Given this list of marker genes Polr3gl, Polr2l, Pou2f1 (POU domain, class 2, transcription factor 1), Gtf3c5, Polr2f, Polr3c, Polr3g, Snapc2, Polr3h, Snapc4, Gtf3c2, Polr2k, Gtf3a, Gtf3c6, Snapc1, Polr3d, Bdp1, Polr3f, Brf2, Snapc5, Polr1c, Gtf3c3, Gtf3c1, Polr2h, Polr2e, Tbp (NCBI Gene Id 21374), Crcp, Gtf3c4, Polr3a, Polr3e, Brf1, Polr3b, Polr3k, Snapc3, here is a description of the gene set: studied in species Mus musculus RNA Polymerase III Transcription Mouse Gene Set: REACTOME_RNA_POLYMERASE_III_TRANSCRIPTION